The following is a description of a gene set: studied in species Homo sapiens Pathway Definition from KEGG: (LHB+CGA) -> LHCGR -> GNAS -> ADCY -> cAMP -> PKA LHCGR-GNAS-PKA signaling pathway. Pathway ID: N00885. Pathway type: Reference. Pathway class: nt06323 KISS1-GnRH-LH/FSH-E2 signaling. Human Gene Set: KEGG_MEDICUS_REFERENCE_LHCGR_GNAS_PKA_SIGNALING_PATHWAY, and this is the list of marker genes: ADCY7, LHCGR, ADCY9, ADCY3, GNAS, ADCY4, PRKACB, ADCY1, PRKACA, ADCY8, ADCY5, LHB, ADCY2, PRKACG, CGA, ADCY6